Given this list of marker genes PSMA5 (NCBI Gene Id 5686), AP2M1, CHMP4A, NDC1, TAF2, PSMD6, CD247, PSMD2, gag-pol, GTF2F2, RNMT, SEM1, ERCC3, nef, CHMP5, HLA-A, TAF7, VPS4A, SKP1, PDCD6IP, PSMB2, NMT1, AP1S3, SUPT16H, vpu, vif, ELMO1, SLC25A5, NUP133, ARF1, CHMP4B, POM121C, TAF9, CTDP1, TAF10, PSMA6, CCR5, VPS4B, AP1M1, TAF5, CUL5, NUP62, PSMD14, NCBP1, XPO1, POM121, TAF13, SLC25A6, RANBP2, TCEA1, NUP93, GTF2B, FYN, POLR2F, ELOA, POLR2J, NUP58, AAAS, MVB12A, SUPT4H1, UBC, RNGTT, NEDD4L, NELFE, PSMD1, CHMP7, FURIN, TAF9B, TAF15, PSMD8, PSMD13, TSG101, PSMA7, RANGAP1, RCC1, LIG4, POLR2C, VTA1, PAK2, GTF2H1, TAF6, CCNK, VPS28, SUPT5H, GTF2A1, XRCC6, NUP98, POLR2G, NUP107, RBX1, NMT2, PSMC2, CHMP4C, PSMB1, CHMP3, TAF7L, NUP205, PSMA2, VPS37C, CHMP2B, PPIA, PSIP1, NUP35, PSMC5, PSMD11, GTF2F1, AP1G1, HMGA1, CD28, NUP155, SEC13, NUP188, AP2A1, POLR2L, env, GTF2H5, rev, UBAP1, RAC1, KPNA1, GTF2H4, TAF3, CD8B, CHMP2A, AP2B1, CDK9, BANF1, NUP43, APOBEC3G, PSMC4, POLR2A, PSMB5, ATP6V1H, TAF4, CCNT2, PSMA3, PSMB7, GTF2A2, GTF2E1, gag, FEN1, PSMB4, RAE1, KPNB1, LCK, XRCC5, GTF2E2, POLR2K, AP2S1, NUP37, PSMB6, tat, PSMB3, PSMA4, VPS37D, NUP214 (nucleoporin 214), TAF4B, PSMC1, NUP42, PSMC6, GTF2H3, MVB12B, POLR2D, NUP210 (NCBI Gene Id 79985), UBB, POLR2H, TBP, XRCC4, NCBP2 (nuclear cap binding protein subunit 2), PSMD7, VPS37B, ELL, LIG1, PSMD12, NUP160, AP1M2, RPS27A, CDK7, TPR, NUP50, NUP54, CD4, TAF1, SLC25A4, AP1S1, PSMA1, ELOC, POLR2E, NELFB, SEH1L, ADRM1, TAF8, CCNH (cyclin H), POLR2B, RAN, vpr, CHMP6, BTRC, ELOB, NELFCD, VPS37A, MNAT1, SSRP1, TAF1L, HCK, NUP88, ELOA2, DOCK2, B2M, POLR2I, NUP85, AP1S2, TAF11, TAF12, PACS1, PSMD3 (NCBI Gene Id 94019), NELFA, GTF2H2, CCNT1, ERCC2, PSMC3, NPM1, CXCR4, AP1B1, UBA52, NUP153, AP2A2, RANBP1, here is a description of the gene set: studied in species Homo sapiens part of: Viral Infection Pathways The global pandemic of Human Immunodeficiency Virus (HIV) infection has resulted in tens of millions of people infected by the virus and millions more affected. UNAIDS estimates around 40 million HIV/AIDS patients worldwide with 75% of them living in sub-Saharan Africa. The primary method of HIV infection is by sexual exposure while nonsexual HIV transmission also can occur through transfusion with contaminated blood products, injection drug use, occupational exposure,accidental needlesticks or mother-to-child transmission. HIV damages the immune system, leaving the infected person vulnerable to a variety of "opportunistic" infections arising from host immune impairment.<br>HIV-1 and the less common HIV-2 belong to the family of retroviruses. HIV-1 contains a single-stranded RNA genome that is 9 kilobases in length and contains genes that encode 15 different proteins. These proteins are classified as: structural proteins (Gag, Pol, and Env), regulatory proteins (Tat and Rev), and accessory proteins (Vpu, Vpr, Vif, and Nef) (Frankel and Young,1998).<br><b>HIV infection </b>cycle can be divided into two phases:<br>1. An <b>Early phase</b> consisting of early events occuring after HIV infection of a susceptible target cell and a <br>2. <b>Late phase</b> comprising the later events in the HIV-infected cell resulting in the assembly of new infectious virions. The section titled <b>HIV lifecycle</b> consists of annotations of events in these two phases.<br>The virus has developed various molecular strategies to suppress the antiviral immune responses (innate, cellular and humoral) of the host. HIV-1 viral auxiliary proteins (Tat, Rev, Nef, Vif, Vpr and Vpu) play important roles in these host-pathogen interactions (Li et al.,2005). The section titled <b>Host interactions of HIV factors</b> highlights these complex post-infection processes. Reactome Pathway: HIV Infection